Given this list of marker genes SPDEF, HOXA5, NFIB (NCBI Gene Id 4781), FOXJ1, TP73, KLF2, RBBP9, SOX9, THRB, RBPJ, GRHL2, GATA6, IGF1, FOXA1, NKX2-1, CREB1, KRAS, CTNNB1, LTA4H, IL13, AGR2, COL6A1, TMEM38B, YAP1, FGF10, PPP3R1, SAV1, AIMP2, THRA, ASCL1, here is a description of the gene set: species: Homo sapiens Human Gene Set: GOBP_LUNG_CELL_DIFFERENTIATION The process in which relatively unspecialized cells, e.g. embryonic or regenerative cells, acquire specialized structural and/or functional features of a mature cell found in the lung. Differentiation includes the processes involved in commitment of a cell to a specific fate.